Given this list of marker genes Agk, Gpd2, Pcyt1a, Mtmr4, Pla2g12a, Pcyt1b, Dgat2, Slc44a1, Gnpat, Etnppl, Plekha2, Osbpl8, Crls1, Ocrl (NCBI Gene Id 320634), Mboat7, Osbpl10, Abhd4, Liph, Pla2g2e, Plekha6, Pik3r4, Pik3c2b (phosphatidylinositol-4-phosphate 3-kinase catalytic subunit type 2 beta), Inpp5e, Rab14, Gpd1, Alpi, Synj1, Agpat2, Synj2, Pi4kb, Pla2g3, Tnfaip8l1, Plbd1, Cpne6, Gpam, Inpp4a, Phospho1, Cdipt, Pip5k1c, Slc44a2 (NCBI Gene Id 68682), Inppl1, Mtmr12, Selenoi, Cpne7, Agpat5, Mtm1, Pik3cg, Pip4k2a, Pla2g4b, Ptdss2, Csnk2b, Pip5k1b, Mtmr2, Tnfaip8l3, Chka, Plekha3, Lpcat1, Mfsd2a (MFSD2 lysolipid transporter A, lysophospholipid), Pik3r5, Pi4k2b, Mtmr7, Pld6, Pik3cd, Mtmr14, Pla2g5, Chpt1, Pld2, Abhd3, Pgp, Mgll, Pla1a, Pik3cb, Cpne3 (NCBI Gene Id 97175), Acp6, Etnk2, Lpcat3, Pnpla2, Pla2g2a, Lclat1, Pik3r3, Pip5k1a, Agpat3, Slc44a3, Pla2g1b, Pla2g10, Pten, Mboat2, Pi4k2a, Pitpnb, Cept1, Csnk2a2, Tpte, Miga2, Inpp4b (NCBI Gene Id 234515), Sacm1l, Lpcat2, Gde1, Bmx, Pnpla6, Sbf1, Pnpla3 (NCBI Gene Id 116939), Chat, Plekha4 (NCBI Gene Id 97417), Rufy1, Ddhd1, Pitpnm3, Cpne1, Tafazzin, Pik3r1, Inpp5k, Cds2, Pla2g4f, Pla2g2f, Gpat4, Lpcat4, Pitpnm2, Pla2r1, Pik3r2, Ddhd2, Pi4ka, Fig4, Lipi, Dgat2l6, Ptdss1, Pip4p1, Cds1, Gpd1l, Pemt (phosphatidylethanolamine N-methyltransferase), Pip4k2b, Pla2g4a, Plb1, Plekha1, Inpp5j, Pla2g6, Pip4k2c, Agpat4, Plaat5, Plaat3, Pik3c2g, Hadha, Plekha5, Rab4a, Pik3c3, Pik3ca, Awat2, Inpp5d, Pik3c2a, Dgat1 (NCBI Gene Id 96948), Pla2g4c, Gpat3, Stard7, Tnfaip8, Pla2g15, Lpin2 (lipin 2), Vac14, Mtmr9, Pik3r6, Hadhb, Tnfaip8l2, Pla2g4d (phospholipase A2, group IVD), Chkb, Lpin3, Enpp6, Stard10, Tmem86b, Pnpla8, Pctp, Mtmr3, Etnk1, Agpat1, Slc44a5, Mboat1, Arf1, Plekha8, Pikfyve, Ptpn13, Pla2g4e, Lpgat1, Mtmr1, Csnk2a1, Rab5a, Pcyt2, Arf3, Gpat2, Slc44a4 (solute carrier family 44, member 4), Osbpl5, Mtmr6, Pitpnm1, Plaat1, Pla2g2d, Inpp5f, Miga1, here is a description of the gene set: Mouse Gene Set: REACTOME_PHOSPHOLIPID_METABOLISM studied in species Mus musculus Phospholipid metabolism